The following is a description of a gene set: A protein complex that can methylate lysine-4 of histone H3, and which contains either of the protein subunits MLL1 or MLL2 in human, or equivalent in other species. species: Homo sapiens Human Gene Set: GOCC_MLL1_2_COMPLEX, and this is the list of marker genes: HCFC2, LAS1L, HCFC1, ASH2L, PELP1, TAF4, CHD8, PRPF31, RUVBL1, KANSL1, TAF9, DPY30, TEX10, SENP3, TAF7, TAF1, RNF2, MGA, C17orf49, MEN1, INO80C, KAT8, WDR5, E2F6, TAF6, PHF20, RUVBL2, KMT2A (NCBI Gene Id 79951), RBBP5, MCRS1, KMT2B, MAX